The following is a description of a gene set: Human Gene Set: TRAVAGLINI_LUNG_MYOFIBROBLAST_CELL from publication Travaglini KJ, Nabhan AN, Penland L, Sinha R, Gillich A, Sit RV, Chang S, Conley SD, Mori Y, Seita J, Berry GJ, Shrager JB, Metzger RJ, Kuo CS, Neff N, Weissman IL, Quake SR, Krasnow MA (PMID 33208946) species: Homo sapiens, and this is the list of marker genes: CLU, USP18 (NCBI Gene Id 11274), DKK3, ROBO2, ATP1B1, CNN3, LXN, S100A10, RARRES1, CYSLTR1, WNT5A, THBD, TYRP1, COMP, NOTUM, VIM, SCARA3, LTBP2, CTHRC1, CREB5, COL3A1, ASPN, BCHE, CFH, HS3ST3A1, SLITRK6, SFTA1P, GEM, NTM (NCBI Gene Id 50863), C16orf89, LUZP2, TSPAN8, CCDC146, ANGPTL6, PSTPIP1, WIF1, CD9 (CD9 molecule), TNFRSF19, POSTN, PDLIM3, FGF18, PRELP, TGFBI, NEDD9, TNC, ROBO1, DPT, TGFBR3, VCAN, MMP2 (NCBI Gene Id 4313), COL12A1, PKIG, ALDH2, ENC1, PAMR1, CXCL14, COL1A1, CCDC68, PCSK1N, WDR91, PDGFC, PTGER1, COL16A1, LINC00632, CCN2